Given this list of marker genes ABCB10, UBXN8, NPPC, MEF2A, PPT2, SAMM50, STARD5, PRKCI, BCAT2, PTPN1, PGRMC1, ZNF281, EMC6, DENND10, RABGGTA, ARHGAP4, R3HDM1, SNX4, MSANTD3, GNG2, CAPRIN1, PDF, FKBP15, SUCLA2, YIPF4, TARS2, SNRPA1 (small nuclear ribonucleoprotein polypeptide A'), STOML2, TRAPPC1, TEX101, TEX10, SLC41A2, DEGS1, PPP2R3C, NOL7, DENR, COQ3, UBE2G1, CD48, PPP1CC, MYB, RDH10, DCUN1D5, HSD17B10, ADSS2, ADRA2A, DPH6, PTGES3, NAA38, TOMM7, IMP3, ANXA5, GANAB, TM6SF1, AP1S2, IPO9, UTP20, SMN1, POR, SLC2A8 (NCBI Gene Id 29988), EVX1, PFKL, SMARCC1, SLF2 (SMC5-SMC6 complex localization factor 2), HSD11B1, RPL24, ZNRD2, ANKRD40, ABCB4, CDC42SE2, SURF2, VTI1A, ACADVL, NDUFV2, MRPS34, HDHD2, PON2, NUCB1, TAF9, ELAVL1, MT2A, ACTG2, XPR1, BLTP2, PLD1 (phospholipase D1), RPL12, CKLF, BYSL, ACADM, DEF8, SLC25A51, GTF2H4, MED14, SMIM30, CERS5, MESD, MYDGF, ALG3 (NCBI Gene Id 131416), MCM3, SRSF10, MAPK3, ACACA, MTX1, CAPZA1, CD302, NCF1, PA2G4, ATP5MC1, COPS6, CEP20, GID4, CHID1, PKP2, THRA, BCKDHB, DAP, CWC27, VWA8, FBXO33, TRMT10C, MYL11, TAF13, HBS1L, TXNDC5, COPG1, LRP1, KLB, PAFAH2, RETREG1, ZW10, GATM, SRSF1, YAE1, NEK9, RPL26, IL1RAP, C2orf76, CD320, SEC11A, JAGN1, SEC61G, NCF2, HNRNPLL, HYPK, PIGP, EIF3B, STK16, MRPS14, PALD1, TMEM33, PSMC6 (proteasome 26S subunit, ATPase 6), PSMG3, E2F6, TAF6, IER3, GRK5, SIRPA, MTFR1, PRXL2B, TTC13, UXT (NCBI Gene Id 8409), FAM118B, CFAP184, FBXL6, TADA2A, RPLP2, ATP6V0B, ETHE1, ACOX1, CLPB, LAD1, GNL3, PDIA3, SFXN3, C11orf24, CENPK, PAX5 (NCBI Gene Id 5079), DNAJC9 (DnaJ heat shock protein family (Hsp40) member C9), ST6GAL1, PTPN11, SIGMAR1, RPL38, GORASP1, C2orf49, UBXN2A, TYROBP, ARFGEF1, DRG1, PRMT5 (protein arginine methyltransferase 5), NDUFA4, NFKBIA, MLLT11, LYAR, YBX3, TOP1, DAD1, NOP16, MRPL48, ATP5PO, STUB1, here is a description of the gene set: mouse primary BMDCs were stimulated with tlr ligands and gene expression changes were profiled on Affymetrix arrays from publication Amit I, Garber M, Chevrier N, Leite AP, Donner Y, Eisenhaure T, Guttman M, Grenier JK, Li W, Zuk O, Schubert LA, Birditt B, Shay T, Goren A, Zhang X, Smith Z, Deering R, McDonald RC, Cabili M, Bernstein BE, Rinn JL, Meissner A, Root DE, Hacohen N, Regev A (PMID 19729616) Human Gene Set: GSE17721_POLYIC_VS_GARDIQUIMOD_16H_BMDC_DN species: Homo sapiens Genes down-regulated in comparison of dendritic cells (DC) stimulated with poly(I:C) (TLR3 agonist) at 16 h versus DC cells stimulated with Gardiquimod (TLR7 agonist) at 16 h.